Given this list of marker genes DNAJC10 (DnaJ heat shock protein family (Hsp40) member C10), TXNDC12, MSRB3, CLIC3, MSRB2, MSRA, MSRB1, IFI30, here is a description of the gene set: species: Homo sapiens Catalysis of an oxidation-reduction (redox) reaction in which a sulfur-containing group acts as a hydrogen or electron donor and reduces disulfide. Human Gene Set: GOMF_OXIDOREDUCTASE_ACTIVITY_ACTING_ON_A_SULFUR_GROUP_OF_DONORS_DISULFIDE_AS_ACCEPTOR